The following is a description of a gene set: Human Gene Set: TFEB_TARGET_GENES from publication Yevshin I, Sharipov R, Kolmykov S, Kondrakhin Y, Kolpakov F (PMID 30445619) Genes containing one or more binding sites for (TFEB) in their promoter regions (TSS -1000,+100 bp) as identified by GTRD version 20.06 ChIP-seq harmonization. species: Homo sapiens, and this is the list of marker genes: OSGIN1, IRF2BP2, KRT8P42 (NCBI Gene Id 100418750), ERN1, STING1, USHBP1, LINC02777 (NCBI Gene Id 105378753), TPRG1L, LINC02243, TRIM47, VPS18, SKIC3, NAMPT, SBNO1-AS1, DDIT3, BCR, EGILA, FAHD1, ADAT3, HERPUD1, CNOT8, TDP2, KLHL6, LNPK, RNU6-402P, RCHY1, RN7SL635P, CACYBP, ARHGAP31, PTCH1, TRIM37, PACSIN2, SNRPGP5, SLC25A5P7, CXCL16, SLC25A13, SGK1, PKD1L2, KLK6 (NCBI Gene Id 5653), CXCL2, MIR4439, ENSG00000245651, SIRT1, RBM19, BTBD19, LSM14B, GALE, SMNDC1, SEC11C, MGST3, ASPSCR1 (ASPSCR1 tether for SLC2A4, UBX domain containing), PLD6, DHX35, TSR3, PLAU, FAM167B, NAT8B, CLUAP1, PDCD1LG2 (NCBI Gene Id 80380), NHLRC1, IGF1R, LAMB4, GARS1, HAPSTR1, ABRACL, TNKS2-DT, HMGXB3 (NCBI Gene Id 22993), NREP, CALHM6, CD2BP2, ASXL2, NEK6, MROH1, SWAP70, CEP63, PHLDB1, SMAD1, EIF4G1, NCOA3, DYNLT4, ZNF322, LYPLAL1, ABCB9, HMGA2, ENSG00000282849, TMEM108-AS1, KDM4C, SLC6A6, PZP (NCBI Gene Id 5858), RNF215, WDR62, ILF3-DT, ATP6V0E1, AHNAK2, ZCCHC2, TIMM13, LINC00161, TSPAN4, ACRBP, STRADB, NOCT, BNC2, MRGPRX4, ACAD9, MIPEP, NCOA2, CAPN7, CREM, PKM, SUB1, DOLK, MORC2, SLC3A2, SPRY2, TAF6L, HABP2, FKBP1A, CPED1, AKR7A2, RITA1 (NCBI Gene Id 84934), PRKAR2B-AS1, SLC49A4, MIR3667HG, PDPR2P, LRIG3-DT, LURAP1L-AS1, HDAC9, RNU6-1231P, TUBAL3, SSH1, SNORD49B, ISLR2, ZNF384, BCL9L, SNIP1, RAB32, LINC02831, SUGCT-AS1, SRRM1, FAM222B, SLC25A33, ACVR1, MYCT1, RIN1, OSBPL8, SLC38A2, MYO18B, UBXN6, TRAC, HOXA9, PIGW, RNASEK-C17orf49, VPS11, ATP6V0A1, DPY19L3, LINC01828, RN7SL346P, RHOT1, RIMKLB, ZCWPW1, COMMD4, ENSG00000272008, FAM118B, UTP15 (UTP15 small subunit processome component), PSMD9, ANKRA2 (NCBI Gene Id 57763, ankyrin repeat family A member 2), ITPR1, EIF4A3, FAM21EP, SMASR (SMAD3 associated long non-coding RNA), ZNF239, UQCRH, FNIP1, MIR548AQ, SEPTIN7P12, JAK1, APOLD1, MECP2, SNX13, NUP188, RNASEK, RNU4-9P, CDKN2C (cyclin dependent kinase inhibitor 2C), ERBIN, ZNF76, KCP, WDR90, ENO3, MIR3934, ZC3H11A, ST13, CNRIP1, MIR193A, ATP6V0C, SLC38A2-AS1, RRAGC, TSGA10, CASC15, UVRAG, SPATA12 (NCBI Gene Id 353324), HNRNPL, EIF3A, GMFB, NEURL2, ST3GAL6, TMEM17, USP31, AP3D1, CLTC, BLOC1S6, TRPM7, LINC01366, CACNA1A, SSR1, MRPL20, GNA15-DT, CUL9, MICU1, FRMD3, TADA1, RND3, KAT14, ZBTB1, SMAD6, PTPRM, RALGPS1, C19orf47, ENSG00000222095, ATP6V1H (ATPase H+ transporting V1 subunit H), LINC03099, H2AZ1-DT, FCGRT, NAB2, CXCL11 (NCBI Gene Id 6373), PAM, CTSA, LRP1-AS, ARFGEF2, APEX1 (apurinic/apyrimidinic endodeoxyribonuclease 1), RMND1, CHCHD2P6, PIGX, MRPS18B, LINC01619, GZF1, GCNT2, HECW2-AS1, HOXA11-AS, CHCHD3, MIR7849, HMOX1, KHDRBS1, NFX1 (NCBI Gene Id 94733), ZNF263, PPP2R1B, ATF4, MAST1, TSNARE1, BCL2, INPP4B, LRBA, NR1D2, TRIB1, ENSG00000253028, EXD3 (exonuclease 3'-5' domain containing 3), NUTM1, CDKL3, GPX1 (glutathione peroxidase 1), PPIP5K2, ZNF280D, INKA2, DOCK5, SLC25A16, MED15, NFATC3, PIKFYVE, EPHA4, STK10, GIGYF2, ORAI2, TUBB4B, CORO7-PAM16, TBC1D9, LINC01480, HNRNPD, RCBTB2, RPL27, ERVFRD-1, ANXA4, CUTA, SLC25A46, CCNL1, TMEM273, MTHFR, AP3M2, DISC1FP1, RN7SKP11 (RN7SK pseudogene 11), CMC2, CYBRD1, LASTR (NCBI Gene Id 105376382), SLC16A1-AS1, NR1D1, IL4I1, ENSG00000267882, PLEKHA7, EFHC1, STAT1, FBXO31, RAB7A, ZFPM2-AS1, VEGFB, GBA1, ESRRA, ALDH1A2, DYRK1A, EFCAB13-DT, EXOC1, MGLL, TRAJ7, TRPC4AP, TNFRSF14-AS1, KLKP1 (NCBI Gene Id 606293), LRRC8A, UBE3D, DNAH12, ANKRD1, CATSPERB, NRP1, GNPDA1, SIRPB2, ADAMTS6, E2F6, EIF3K, ACCS, ENSG00000245025 (NCBI Gene Id 107984124), SKAP2, KLF6 (KLF transcription factor 6), LINC02611, ENSG00000259072, LRRC37B, RETREG2, ENSG00000266401, NRROS, FAM21FP, NPTN, SKIL, PRR5L, BRI3, RNU1-108P, SPHK1, HEXA-AS1, ZNF24TR, THAP8, CCRL2, ANAPC13, UBE2D3, TUBB6, IFI27, FDX2, CLUH, ARAP3, SPATS2, TPP1, FAM72A, BAX (NCBI Gene Id 581), ABL2, OXCT1, MYO1E, IL34, ATP13A3, EPG5, TRAF5, FEZ2, MTHFD1L, CACUL1, CREBRF, CD5L, ABR, SRGAP3, MILIP, SERF2, LINC02392, APLN, LMNA, CEP120, TRAK2, IGF2R, APH1B, RPUSD4, CLN3, HSP90AA1, FMR1-AS1, DNAH11, RBPJ, GADL1, MBD6, PRKCB, RMC1, WASHC2A, VAPA, FAM3D, LRRC41, U2SURP, BBS5, MDM2, NLRC5, BTK, HIF1A, MEPCE, PDCD6, COX6CP5, DAZAP2, UQCC6, FAM210A, NAMPT-AS1, NOS3, RNA5SP40, TBC1D13, RAPGEF2, DUSP1, WASHC2C, SLC38A6, SUMF1, C16orf74, PRECSIT, KAT5, MFSD11, MAPK3, HIBCH, SLC35F6, SLC16A13, CAST, ARHGEF28, TCF12, LBX2, GPM6A, ZNF507, GNL1, KAT6A, MCTP1, RNU6ATAC32P (NCBI Gene Id 106479556), GABARAP, TGFBI, LACTB2, HNRNPH2, CATSPERD, ARMT1, OAT, LSM5, CTNNA1, BROX, SEZ6, TXNL1, FAR2, IGF2BP3, SLC51B, SLC36A1, CARD8, TMEM241, BSG, HAGH, ATP6V1G1, ZBTB38, FAM149B1, LINC01730, HEXB (hexosaminidase subunit beta), KLHL12, COX7A2, CTSB, TOP1MT, LRIG3, CFLAR-AS1, GALNS, TRAPPC8, LINC02709, KIF17, PTGR3, WASHC5, FOXJ3, STAT3, ERCC1, ATP6V1E1, TRAV13-2, ZC3H18, C1orf43, ATF5, ENAH, MAP2K4P1, PICALM, HOXA11, COL27A1 (collagen type XXVII alpha 1 chain), MFSD4B-DT, SLC12A8, TBX15, SLC7A8, ENKUR, MIR27A, RPAP2P1, ACOT7, MIR6821, TBC1D15, CAP1, SULT1B1, PRR3, ATG3, PTPA, EFHD2-AS1, RRAGB (NCBI Gene Id 10325), PCID2, C1QTNF6 (NCBI Gene Id 83847), ELP2, RPL30P11, DANCR, LMNB1, DIAPH1, WDR37, TINAGL1 (NCBI Gene Id 64129), MPG, SNX16, SRD5A1, LINC00963, CLIP4, CNIH3, ARL8B (NCBI Gene Id 55207), SF3B5, FNBP4, EP300, GNG12-AS1, GBE1 (1,4-alpha-glucan branching enzyme 1), KHSRP, DROSHA, ATP6V1D (NCBI Gene Id 51382), AMPD3, WDR81, NUDT9, CLN6, PEPD, EGLN2, LINC00649, METTL6, PLEKHO1, PRPSAP1, KIF23-AS1, RNF185, MIATNB, OTUD3, NSMCE2, RACK1, BCL2L13, SLC35E3, MLST8, NDUFAF6 (NADH:ubiquinone oxidoreductase complex assembly factor 6), SEPTIN9, IDH1, ATP6V0D1-DT, MFSD4B, MTUS1, JMJD1C, TPRA1, NNT, REV1, SMIM27, DENND1A, SH2D5, C6orf52, DCAF13, PPP3R1, DAB2, ZNF512, MIR151A, RDH13 (NCBI Gene Id 112724), XPO1, ARHGAP12, ARSK, PISD, EIF2S1, PPP1R18, ENSG00000267764 (NCBI Gene Id 105372105), TLCD3A, GLMP, ENSG00000253214, MAFB, MIR23A, MED28-DT, TIGD6, TAMALIN, EHMT2, GLA, LNCOG, SDE2, LRRC37A3 (leucine rich repeat containing 37 member A3), CRBN, SLC35A5, MFNG, EDN1, RNF166 (NCBI Gene Id 115992), GET4, CUL4B, MDM4, SCAF11, SPPL3, ALS2, ATP13A3-DT, TRBV13, SYNRG, TGFBR2, KIAA1217, NAA50, MYH9, ADTRP, GIT2, FGGY, RPL7AP83, CD63-AS1, LNCTSI, CIPC, WAC, CTSD, LYSET (lysosomal enzyme trafficking factor), SMAD3, BANF1P1, RNU6-92P, HERC5, STX6, HPS1, HMG20A, PCNX4-DT, TRMT5, H2AZ1, TRIP6, HM13-AS1, OSTM1, PLEKHM1, KLF4, LINC00964, FAF1, MAPRE2, LINC00974, MIR3142HG, SCG5, CCN3, SMIM2-AS1, SRGAP2, LINC02525, VPS26C, ZBTB40 (zinc finger and BTB domain containing 40), ITGA7, PPFIBP2, SLC25A32, CROCCP2, RN7SL237P, MFSD1, NOL8, CHIC1, LINC00607 (long intergenic non-protein coding RNA 607), SYNCRIP, FAM169BP, SLC16A1, USP36, DPP7, COL12A1, RPS6KA3, PRMT3, PPP1R10, LTBR, ENSG00000260005, P4HB (prolyl 4-hydroxylase subunit beta), DMAC2L, KLHL5, STX4, GTF2A1, PARVB, GATD1, MCOLN1, SCAMP5, FTL, ESRP2, ZNF483, PLCG1-AS1, CAHM (NCBI Gene Id 100526820), PANK3, CORO7, HDAC5, MAGI2-AS3, MACORIS, TUBB, ATP2B1, SHPK, USP32 (NCBI Gene Id 84669), JAM3, FBXO24, LINC02404, SLC25A38, SLMAP, ITPR2, UBAP2, PUM2, SLC38A7, TSR2, THUMPD3, ILF3, ARHGAP23 (Rho GTPase activating protein 23), ICAM2, WSB2, LINC00520, YAP1, MIDN, CASP4, DDX54, LZTFL1, SUSD1, UBA52, TFB1M, FARP2, IFIT3, STMN1, PPID, NAV3, SH3TC2-DT, VPS41, PPT1, ACIN1, LINC00702, STK4, WASL, SCAMP4, ZNF503-AS2, ZNRF3-AS1, ENSG00000258623, GATD1-DT, WLS (Wnt ligand secretion mediator), AKNAD1, CHCT1, UVSSA, NINJ2, TLR4, KLF3, GARS1-DT, TACC3, GPR137B, LTBP1, ECD, PPP4R1L, GMNN, VPS37B, TBL1X (transducin beta like 1 X-linked), RAB31, PDXK, UBE2Q1, PCNX4, ANKRD50, ITGA5, LINC02909, HPS3, GEM, ALG1, ENSG00000240687, GOLGA1, RAD23A, DUSP6, DHX35-DT, ACOX1, SLC22A18 (solute carrier family 22 member 18), MED28 (mediator complex subunit 28), HNRNPD-DT, HRG-AS1, LINC02615, PRCP, BRCA2 (BRCA2 DNA repair associated), CORO1C, ELP3, SSBP3, BBX, LONP1, CCNB3, AFF4-DT, NRAS, CRACD, CCDST, SH2D3C, MIEN1, UBE2R2, PHTF2, MRPS31, TMCC3, RGS5-AS1, BPTF, SGMS1-AS1 (SGMS1 antisense RNA 1), ACAP2, GALT, DYRK4, STAT6, NRBP1, GFI1B, IGLV3-24, ETV6, RPL36AL, MT2A, MRPS15, MAPK13, GADD45G, NINJ2-AS1, SEC14L1, HMGA1, FBXO30 (NCBI Gene Id 84085), OSGEP, LINC02965, STRADA, C4orf46P2, SUPV3L1, NPM1P21, RN7SKP192, ZNF775, ZEB1, STAB1, VAC14, DNPH1, LINC01013, LINC02541, DUSP3, GSK3B-DT, S100A6, PHKB, FUBP3, CEP135, ARIH2OS, RNA5SP44, POLA2, SLEAR, RRAGC-DT, ENSG00000262231 (NCBI Gene Id 105371508), RNMT, NFATC4, KBTBD2, SNHG29, KLHL3, ACOD1, STK4-DT, RALB, RIMOC1, PHF20L1, RNF220, CLEC2B, ZC3H4, DIAPH2, SNORA26, CXCL8, POMT1, UTP11 (UTP11 small subunit processome component), CFAP161, UAP1L1, HELQ, LINC-PINT, S100A2, PRKCH, PDCD6-DT, CELF1, ADCK1 (aarF domain containing kinase 1), JOSD1, MAPK6-DT, PRDX5, HSPBAP1, GTDC1, CALD1, MIR584, TG, SYNJ2, NAGPA, CLCN7, MGAT2, PICSAR, NCKAP1, XPNPEP3, SGMS1, PFN1, PRRC2C, COX5A, SIGLEC15, LINC02643, ALOX5AP, ENSG00000252904, NMRAL1, DUSP4, ZBTB17, MIR548AW, CC2D1B (coiled-coil and C2 domain containing 1B), RNU6-1105P, KU-MEL-3, LARP1, RAET1E, NAP1L1, LINC02705, SP140, MFF, FLRT2-AS1, TMEM116, NAV2-IT1, CPA3, ARHGEF2, HOXA-AS2, NDUFV2, WASHC4, ENSG00000257746, NNT-AS1, GALNT10, PAWR, DLG2, LINC03002, RAPGEF6, PLEKHB2, TNKS2, HMGB1P50, ESM1, PGAP6, RAB5A, GATAD1, MICALL1, FHIP1B, ERP29, NAPA, RHOJ, C9, ARHGDIA, TBC1D5, PHC3, HCFC1R1, MAX, GDF15, SNORD3J, CYREN, ABCC2, FAM124B, SPART-AS1, ZSWIM8, CD63 (CD63 molecule), CDH5, CUEDC1, CORO1B, PIP4P2, HOXA5, PATL1-DT, VPS33A, NHLRC2, DOCK9, SBNO1, CAMK2D, AMZ2P1, ENSG00000276170, REPIN1, FLCN, MAPK6, PPM1H, MAPKAP1, ATP6V0D1, PPP1R12B, SDAD1P1, LATS2, EHD1, VMP1, IRF9, SPG11, KCTD5, BAALC, HPS4 (HPS4 biogenesis of lysosomal organelles complex 3 subunit 2), SLC22A5, VPS26A, TXNRD2, BEST3, ZNF292, LINC02915, EFHD2, LEMD2, ADGRG1, SLC48A1, AFF4, CDK14, RBFOX2, WBP1L, ELDR, LONRF3, LINC02487, SRRD, LIPT1, SQSTM1, APC, RNASE6, FGGY-DT, ILVBL, LINC00322, OR5B15P, RAET1K, UGGT1, LINC01615, FOSL2, ADAMTS3, SSTR5, NEMP1, ID2-AS1, PLEKHA6, WDR6, NFIA, KLK9, AMDHD2, INSIG1, PLSCR4, TNFAIP3, G6PC3, ENSG00000255491, RPL26P20, MED24, CENPP, FAM83G, CLIP1 (CAP-Gly domain containing linker protein 1), CYSTM1, MIR378D2HG, MAPK12, RPL19, RASGRP3, AHI1, LINC01812, USP9X, SAE1, ANKRD28, ENSG00000266313, DLC1, MAEA, GNB2, ENSG00000268129, FABP4, EFHB, B3GAT3, IP6K1, GTF2A1-AS1, STIP1, UBAP2L, UBE4B, RBM15B, PDZRN3, HIVEP3, ZSCAN9, ANPEP, YOD1, HIVEP1, FAXDC2, TUBA1B-AS1, RPL8P5, RAB21, NUP62 (nucleoporin 62), LYPLAL1-DT, WEE1, HSDL1, CLCN6, SDHC, EPAS1, SLC66A1, TUBA1B, GABBR2, GAPLINC, EFEMP1, F13A1, LIG1, EPM2A-DT, XXYLT1, TOP3A, DNAJB5, GALK2, TSHZ1, LAMTOR4, LINC01748, RN7SKP190, SNX8, UTP25 (NCBI Gene Id 80064), VSIG10, VPS16, PCGF2, TRIB3, ZNF503, TUT1, LDLRAD4, CSF3, COMMD3, PET117, BNIP3L, MAPKAPK3, SHKBP1, SPART, ARRB1, HNRNPF, PTP4A2P2, GATAD2A, ECE1, GTSF1L, HPN, LRP1, TRAPPC2L (NCBI Gene Id 51693), CFAP251, CD2BP2-DT, ACTN2, SMCR8, TPM3, MYO19, NDUFV2-AS1, PGK1, SEMA6B, EVA1C, ZNF316, LIMK1, TSC1, ENSG00000261195, MCM2, ZSCAN21, GIN1, XIRP2-AS1, RGS12, C6orf62, HTATIP2, SSR3, ABHD12, PKD1L1, MAP1LC3B, CEP162, CCDC82, MIR222HG, GRN, ARAP1, ENTREP1, CFDP1, UTP4 (NCBI Gene Id 84916), RNU6-174P, CCDC9, CTNS, OTUD7B, NOP10, PNISR, AVL9, PLD3, PIP4P1, TMC8, MIR23AHG, HPS5 (HPS5 biogenesis of lysosomal organelles complex 2 subunit 2), RNU6-1300P, SLC38A4-AS1, SLC7A5, SDAD1, ATXN3, MAP4, HHEX, TOMM20, CEP164, KIFC1, ATP6V0E1P1, MYL12A, CMIP, UACA, SLC35B2, LINC00431, TEX10, AXL, EPC1-AS1, MIR3928 (microRNA 3928), MTDH (NCBI Gene Id 92140), KLHL6-AS1, CALCRL-AS1 (NCBI Gene Id 105373786), SNX2, TRIM25, EFCAB13, RAI14, AOPEP, SIK3, BBS9, NEAT1, PIGT, LAMTOR3 (NCBI Gene Id 8649), PRKAR2B, ISG20, SLC33A1, LINC00310, OPN5, MAFG, TM9SF3, ATP6V1C1, DENND6A, SAMD4A, GTF2F2, COMMD3-BMI1, ITGAX, TBC1D8, HSD17B14, TBC1D17, EMC2, UBE2B, BHLHE40 (NCBI Gene Id 8553), TRD-AS1, UBA7, GP6, LINC01132, AIDA, CUL5, ZNF318, MAPK1, PATL1, FMR1, MIR3189, CD68, NEU1, AP5Z1, TNRC6B, GAA, MRPL36, EIF5A2, TMEM126B, CNPPD1, PRICKLE2-AS3, DDX39A, CD34, CD164 (CD164 molecule), ERG, TNS1, MAP4K1, RUSC2, GNS, GTF2H1, QKI, DVL2, DBP, SRSF2, LIMS1, CREB3L4, CCDC125, ATP6V0B, KANSL1L, BSG-AS1, TMEM232, RDH10-AS1, HS1BP3, SLC16A5, ANKRD11, MCRIP1, TRPV2, CP, SLC6A12, ARFIP1, KRT36, BMI1, GLT8D2, ENSG00000259182, BLOC1S1, ATIC, WDFY4, PCED1A, ELK3, PGM1, MALAT1, ENSG00000270174, RCBTB1, ADAMTSL4-AS1 (ADAMTSL4 antisense RNA 1), TRMT112, DNAAF1, PDE7B-AS1, KLHL22, SLC25A45, TBCEL (tubulin folding cofactor E like), ATP5MGP8, THNSL1, MSANTD3, ACP5, PHF3, RAPGEF3, ADAMTS18 (ADAM metallopeptidase with thrombospondin type 1 motif 18), DENND6A-DT, RHBDF1, PNKP, MEF2C (myocyte enhancer factor 2C), CENPA, DUSP7, DNAJC13, PCM1, APP-DT, NSMAF, CD22, ZBTB25, ANKRD12, ZNF669, STEAP1B, EAF1-AS1, YES1, RPS9, SMYD5, ROBO4, HEXA, CYP2C61P, HBP1, PDP1, RUNX1T1, HCFC2, MGST2, NSUN2, ASAP1, METTL13, TAF4B, TMC6, HOXA7, WWP2, PEX5, FLRT2, PSMD1, CDKN1B, MFF-DT, GAPDH, MARF1, CDK4, SPG7, BOD1, CANX, MTCH2 (NCBI Gene Id 23788), SLC2A3, SERPINE1, SH3BP5, CLTA, SPOCD1, LY96 (lymphocyte antigen 96), RFX2, AKT1S1, PDE12, DGKI, SNHG7, CACNB1, KIFC3, RARA, SSTR5-AS1, LAMC1, GASAL1, RPL10P7, SORBS1, EPC1-AS2, DND1P1, TNFRSF14, OSER1, ALKBH3-AS1, LPIN2, WAC-AS1, NAGLU, IRS2, TRPM1, TCF4, TMEM161B, EIF4E, LCORL, APP, VPS11-DT, HOXD10, CAMTA1, EIF4B, ATP7A, THAP6, XKR9, ZBTB8OS, CASP12, ID2, RELB, HECW2, ACOT13, LAMP1, LAMTOR1, SNRPE, LINC03108, COL6A4P1, ATP6V1A, SLC2A13, PLIN2, MRPS18C, DCK, DLGAP1-AS2, PIAS4, FAAP100, ARMCX1, RELL1, ICAM1, DPY19L3-DT, RERE, ZBED6, LYPD1, ZNF622, MFSD14A, PPP1R3E, GIPC1, ZNF836, CCR5AS, COPRS, MARK1, MOAP1, MST1P2, LY6K, GOLGA4-AS1, OSER1-DT, C2, MYOM3, SPNS1, MAFK (NCBI Gene Id 7975), ZNF521, ZAR1L, ATP6V1B2, RAD9A, BFSP1, PRPF3, BACH1, CISD2, NUDCD3 (NudC domain containing 3), IFI16, ZNF438, CLDN6, GUF1 (GTP binding elongation factor GUF1), RBBP4, SLC16A7, EDEM1, GNPTG, CHM, AKAP13, RNY4P14, CRCP, SH3BP4, KIF23, TNPO2